The following is a description of a gene set: Human Gene Set: GOBP_POSITIVE_REGULATION_OF_PROTEIN_SERINE_THREONINE_KINASE_ACTIVITY Any process that increases the rate, frequency, or extent of protein serine/threonine kinase activity. species: Homo sapiens, and this is the list of marker genes: IRGM, ERN1, FGF18, TENM1, TRAF6, MAP2K2, IFNG, EZH2, PIH1D1, RHOA, CCNY, MAP3K10, MAP3K7, TPD52L1, SASH1, DRD4, MAP3K11, FGF1, FLT3, PDGFRB, NEK10, CRIPTO, MAP3K5, PDGFB, FGFR1, DIRAS1, ELANE, ARHGEF5, PDCD10, CAB39, DIRAS2, SYAP1, PSMD10, LTF, HMGA2, TLR6, TNF, MST1R, TCIM, SRC, S100A12 (NCBI Gene Id 6283), WNT5A, MAP2K1, ETAA1, PIK3CG, PIK3R5, CIB1, ADIPOQ, MAP4K2 (mitogen-activated protein kinase kinase kinase kinase 2), PTPN1, CEMIP, TAOK3, RALB, CAMK1, TRAF2, SIRT1, FGF2, DIPK2A, FLT1, PIM1, MAP3K4, RAPGEF2, ERBB2, PIK3R6, RASGRP1